Given this list of marker genes OPA1, BCL2, STAT6, RAG2, FOXP3, PRKDC, BRD4, IL7, LOXL3, CYLD, ZFPM1, LGALS1, IL6R, EP300, SHH, TBX21, MTOR, CD69, BRAF, TNFSF18, STAT3, TP53, RHOA (ras homolog family member A), SOCS3, JAK1, IL6ST, CTSL, TOX, STAT5A, BATF (NCBI Gene Id 10538), IL23R, FOXN1, SLAMF6, SPN, IL23A, IRF4, IL12RB1, BRD2, IL6, JAK3, LY9, IL12B, here is a description of the gene set: species: Homo sapiens The process in which a lymphoid progenitor cell becomes committed to becoming any type of T cell. Human Gene Set: GOBP_T_CELL_LINEAGE_COMMITMENT